Given this list of marker genes PTPN3, ROS1, DCDC2, MYO5B (NCBI Gene Id 4645), RFX6, HSD3B7, BRCA1, BRCA2, CYP7B1, here is a description of the gene set: Clay colored stools lacking bile pigment. Acholic stools studied in species Homo sapiens Human Gene Set: HP_ACHOLIC_STOOLS